The following is a description of a gene set: N-Glycosylation is one of the most common co- and posttranslational modifications of eukaryotic proteins occurring in the ER lumen. N-glycosylation plays pivotal roles in protein folding and intra- or inter-cellular trafficking of N-glycosylated proteins. Quality control mechanisms in the ER sift out incorrectly-folded proteins from correctly-folded proteins, the former then destined for degradation. Incorrectly-folded N-glycans are exported to the cytosol where the process of degradation begins. Once the unfolded protein is cleaved from the oligosaccharide (forming free oligosaccharides, fOS), step-wise degradation of mannose moieties, both in the cytosol (Suzuki & Harada 2014) and then in the lysosome (Aronson & Kuranda 1989, Winchester 2005), results in complete degradation. Breakdown must be complete to avoid lysosomal storage diseases that occur when fragments as small as dimers are left undigested. Reactome Pathway: Lysosomal oligosaccharide catabolism species: Homo sapiens part of: Metabolism of carbohydrates and carbohydrate derivatives, and this is the list of marker genes: MAN2C1, MANBA, MAN2B2, MAN2B1